The following is a description of a gene set: Human Gene Set: REACTOME_CDC6_ASSOCIATION_WITH_THE_ORC_ORIGIN_COMPLEX CDC6 association with the ORC:origin complex studied in species Homo sapiens, and this is the list of marker genes: CDC6, ORC2, ORC1, ORC6, ORC5, ORC3, MCM8, ORC4